The following is a description of a gene set: Spasticity is manifested by increased stretch reflex which is intensified with movement velocity. This results in excessive and inappropriate muscle activation which can contribute to muscle hypertonia. Spastic gait is characterized by manifestations such as muscle hypertonia, stiff knee, and circumduction of the leg. studied in species Homo sapiens Spastic gait Human Gene Set: HP_SPASTIC_GAIT, and this is the list of marker genes: SACS, CTCF, SHMT2 (NCBI Gene Id 6472), GBA2, CYP2U1, NIPA1, POLR3B, KIDINS220, CACNA1G, TECPR2, MAG, ERLIN1, ATL1, REEP2, AMPD2, ZFR, HSPD1, SLC33A1, CPT1C, WDR48, NT5C2, SPAST, B4GALNT1, CCT5, SPART, TMEM63C, CYP7B1, ARL6IP1, PLP1, KIF1A, UBA5, FBXO7 (F-box protein 7), BSCL2, LMNB1, SLC25A15, PLAAT3, FARS2, RETREG1, SPTAN1, ARSI, NSUN2, DDHD2, VAMP1, WASHC5, SPTSSA, ATAD3A, GJC2, ERLIN2, ERCC6, MFSD2A, TACO1, KCNA4, SPG7, UBAP1, DSTYK, WDR26, ALS2, ATP6AP2, ARG1, VCP, ZFYVE26, WLS, RTN2, REEP1, USP8, SLC39A14 (solute carrier family 39 member 14), ABCD1, DDHD1, FUCA1, KIF5A, MECP2, PGAP1 (NCBI Gene Id 80055), SPG11, AP5Z1, ALDH18A1, KPNA3, APC, KCNA1